The following is a description of a gene set: studied in species Homo sapiens Heat intolerance The inability to maintain a comfortable body temperature in warm or hot weather. Human Gene Set: HP_HEAT_INTOLERANCE, and this is the list of marker genes: ALOXE3, EDAR, MAP2K1, HNRNPK, PI4K2A, MAP2K2, KRT5, EDA, SHANK3, OCA2, LDHA, POFUT1, UBE3A, ORAI1, ZMYM3, NECTIN4, KRT14, CLDN10, MBTPS2, PSENEN, EDARADD, ITPR2, POGLUT1, LBX1, NFKBIA